Given this list of marker genes TNF, ALOX5 (NCBI Gene Id 240), TNFAIP3, MIR451A, SLC12A2, MIR34A, FOXC2, MIR200B, TAFA5, SERPINE1, MIR1298, VEGFB, SMOC2, HTN1, XBP1, here is a description of the gene set: species: Homo sapiens Human Gene Set: GOBP_REGULATION_OF_VASCULAR_WOUND_HEALING Any process that modulates the rate, frequency, or extent of blood vessel formation when new vessels emerge from the proliferation of pre-existing blood vessels and contribute to the series of events that restore integrity to damaged vasculature.